Given this list of marker genes ADAM7-AS2, STMN4, DNAJB6P2, SLC39A14, LGI3, SCARA5, RNU1-148P, HRURF, BIN3, RNU6-1086P (RNA, U6 small nuclear 1086, pseudogene), COX6B1P4, ADRA1A, TNFRSF10A, FBXO16, ADAM28 (ADAM metallopeptidase domain 28), ENSG00000289521, LOXL2-AS1, GNRH1, INTS9, ELP3, R3HCC1, EPHX2, DOK2, NEFM, LINC03023, TNFRSF10B-AS1, NUDT18, ENSG00000253775, DOCK5, PIWIL2-DT, ENSG00000286346 (NCBI Gene Id 124901902), ENSG00000284948, ENSG00000245025, PPP2R2A, TMEM97P2, TNFRSF10A-AS1, NPM2, LINC02153, DMTN, PHYHIP, OR6R2P, C8orf58, RNU6-1276P, BNIP3L, RNU6-178P, RPL21P77, MIR320A, BTF3P3, CHRNA2, SFTPC, ENTPD4, SLC18A1, SLC25A37 (solute carrier family 25 member 37), PEBP4, CDCA2, PNOC, KCTD9, PPP3CC, DPYSL2, HMBOX1-IT1, SH2D4A, MIR4288, RNU6-336P, LZTS1-AS1, ADAMDEC1, RNA5SP259, TNFRSF10D (NCBI Gene Id 8793), CLU, RPL30P9, MIR6842, LPL, RNA5SP258, ENSG00000253397, NKX2-6, GFRA2, ENSG00000248738, RPL23AP55, PTK2B (protein tyrosine kinase 2 beta), GULOP, REEP4, MIR6876, LINC03093, TNFRSF10C, HR, MIR3622B, FHIP2B, MIR4287, FZD3, POLR3D (NCBI Gene Id 661), SINHCAFP3, CSGALNACT1 (chondroitin sulfate N-acetylgalactosaminyltransferase 1), RN7SL303P, RPL36AP32, PBK, ADAM7, ENTPD4-DT, RHOBTB2, NUGGC, MIR548H4, BMP1, TRIM35, NKX3-1, TNFRSF10A-DT (NCBI Gene Id 389641), EBF2, EXTL3, ADAM7-AS1 (NCBI Gene Id 101929294), ESCO2, INTS10, PIWIL2, XPO7, HMBOX1, PSME2P5, ENSG00000253270, INTS9-AS1, RNA5SP257, ZNF395, NEFL (neurofilament light chain), SCARA3, SORBS3, LOXL2, MIR6843, PDLIM2, ENSG00000253986, STC1, RNU6-892P (RNA, U6 small nuclear 892, pseudogene), RNU4-71P (RNA, U4 small nuclear 71, pseudogene), RPL5P22, MIR6841, CCDC25, CCAR2, EGR3 (NCBI Gene Id 1960), PNMA2, FGF17, MIR3622A, EXTL3-AS1, SDAD1P1, TNFRSF10B, ENSG00000308775, ATP6V1B2, CHMP7, ENSG00000253557 (novel transcript), LZTS1, here is a description of the gene set: Human Gene Set: chr8p21 species: Homo sapiens